The following is a description of a gene set: The clustering process in which postsynaptic density protein 95 (PSD-95) molecules are localized to distinct domains in the cell membrane. PSD-95 is mostly located in the post synaptic density of neurons, and is involved in anchoring synaptic proteins. species: Mus musculus Mouse Gene Set: GOBP_POSTSYNAPTIC_DENSITY_PROTEIN_95_CLUSTERING, and this is the list of marker genes: Nlgn2, Cript, Lrrc4, Nlgn1, Reln, Cit, Slc30a1, Dbn1, Nrxn2, Nrxn1, Cdh2, Zmynd8